The following is a description of a gene set: Combining with epinephrine or norepinephrine to initiate a change in cell activity via activation of a G protein, with pharmacological characteristics of alpha-adrenergic receptors. studied in species Mus musculus Mouse Gene Set: GOMF_ALPHA_ADRENERGIC_RECEPTOR_ACTIVITY, and this is the list of marker genes: Adra1b, Adra2c, Adra1d, Adra2a, Adra1a, Adra2b